The following is a description of a gene set: Verrucae species: Homo sapiens Warts, benign growths on the skin or mucous membranes that cause cosmetic problems as well as pain and discomfort. Warts most often occur on the hands, feet, and genital areas. Human Gene Set: HP_VERRUCAE, and this is the list of marker genes: CD28, CD4, IGLL1, LRRC8A, GATA2, SASH3, CD79A, POLD1, CD79B, STK4, CIB1, IGHM, RNF31, SEC61A1, IVNS1ABP, CARMIL2, BLNK, CXCR4, TMC6, IKBKG, TCF3, PIK3R1, ATP2A2, RHOH, TMC8, SLC39A7, IL7, FCN3, PDCD1, DCLRE1C, SPI1, ECM1, ICOSLG, DOCK8